The following is a description of a gene set: Activation of NMDA receptors (NMDARs) leads to activation of AMP-activated kinase (AMPK) in a CAMKK2-dependent manner. Overactivation of CAMKK2 or AMPK in neurons can lead to dendritic spine loss and is implicated in synaptotoxicity of beta-amyloids in Alzheimer's disease. studied in species Homo sapiens Reactome Pathway: Activation of AMPK downstream of NMDARs part of: Post NMDA receptor activation events, and this is the list of marker genes: TUBB6, TUBA3D, MAPT, PRKAB2, TUBB8B, TUBA4A, TUBB4B, TUBAL3, PRKAA2, PRKAA1, PRKAG2 (NCBI Gene Id 7981), TUBA1A, PRKAB1, TUBA3C, TUBB1, PRKAG3, CAMKK2, TUBB2B, TUBA1B, TUBB3, PRKAG1, TUBA3E, TUBA4B, TUBB2A, TUBB8, TUBA8, TUBB4A, CALM1, TUBA1C